The following is a description of a gene set: studied in species Mus musculus Mouse Gene Set: GOBP_NEGATIVE_REGULATION_OF_T_CELL_APOPTOTIC_PROCESS Any process that stops, prevents, or reduces the frequency, rate or extent of T cell death by apoptotic process., and this is the list of marker genes: Pnp, Il7r, Ido1, Tnfrsf4, Ada, Arg2, Slc46a2, Jak3, Fadd, Gpam, Dock8, Bcl3, Ccl5, Vhl, Pip, Bcl2, Rag1, Serpinb9, Cd27, Bcl11b, Ptcra, Kifap3, Efna1, Hif1a, Bmp4, Tnfsf4, Prkcq, Blm, Tsc22d3, Rorc, St3gal1